Given this list of marker genes TXNRD2, MRAP, MC2R, BRAF (B-Raf proto-oncogene, serine/threonine kinase), TERT, HFE, RTEL1, ATP6V1B2, MYO5A, KRT14, HAMP, HRAS, POLA1, DKC1, AIP, PAX6, KRAS, AKT1, HJV, STAR, MAP2K2, INSR (NCBI Gene Id 3643), NNT, KRT5, GPR101, PARN, MAP2K1, IRF4, ACD, KCNN3, ALDH3A2, GPNMB, TINF2, CYP11A1, GMPPA, BMP6, TRAPPC11, KCNH1, AAAS, here is a description of the gene set: Generalized hyperpigmentation species: Homo sapiens Human Gene Set: HP_GENERALIZED_HYPERPIGMENTATION